Given this list of marker genes Trp53, Ep300, Ehmt1, Rps27a (ribosomal protein S27A), Chek2, Prmt5, Ubb, here is a description of the gene set: This event has been computationally inferred from an event that has been demonstrated in another species.<p>The inference is based on the homology mapping from PANTHER. Briefly, reactions for which all involved PhysicalEntities (in input, output and catalyst) have a mapped orthologue/paralogue (for complexes at least 75% of components must have a mapping) are inferred to the other species. electronically inferred by orthology from the curated human pathway Reactome Pathway: Regulation of TP53 Activity through Methylation part of: Regulation of TP53 Activity species: Mus musculus